Given this list of marker genes Bcl2, Dpp4, Nlgn1, Tbr1, Cep135, Slc44a3, Cd36, Fgf12 (NCBI Gene Id 320320), Sbno2, Map3k8, Cry1, Add3, Calr4, Pdp1, Atad2b, Tg, Etnk1, Ccp110, Pcdh7, Dr1, Hs3st5, Plin3, Traf3ip1, Rest, Six6, Crtc1, Fbxl14 (NCBI Gene Id 101358), Tyr, H2-M10.6, Slc6a1, Ndst4, Fryl, Wrnip1, Jakmip2, Cep152, Gpm6a, Slc52a2, Atad2, Ube2e1, Neurod4, Agfg1, Foxj3, Kcnc4, Btg3, Zfp711, Ceacam19, Rictor, Tagap1, Dact1, Mindy2, Fbxl17, Zfp354b, Prkcb, Slitrk5, Stxbp5l, Cdk19, Ccnh, Cnksr2, Supt7l, Rab2b, Tceal1, Seh1l, Nbea, Hecw2, Stt3a (NCBI Gene Id 16430), Adam10, Slain2, Nrg3, Cap1, Dnm3 (NCBI Gene Id 98663), Tmppe, Rap2c, Kif21a, Fyttd1, Mfsd6, Otx2, Pde4d, Gabrb3, Bpnt2, Slc6a19, Dennd1b, Cysltr1, Elf2, Sh3kbp1, Rab7, Gm6377, Dapk1, 1700010I14Rik, Tbx3, Spock3, Peli1, Lman2l, Kcnmb2, Fermt2, Plp1, Etv1, Kbtbd7, Gucy2f, Vash2, Cyth3, Mcee, Plscr4, Taf1b, Kctd9, Azin1, Cxadr, Extl3, Tspan12, Bmpr1a, Zfp763, Mbp, Srsf11, Ssbp2, G3bp2, Csrnp1, Tmprss11a, Cav1, Crppa, Ino80d, Tshz1, Fam184b, Tagap, Pip4p2, Zfp521, Porcn, Pcdh10, Gatm, Apobec3, Pdlim5, Slc35f4, Cdh7, Kcnv1, Adgrl3, Ankrd42, Rngtt, Aldoc, Klhl5, Prkab2, Apbb2, Nbl1, Tex12, Ntf3, Kcna4, Nwd1, Klhdc2, Nfia, Hnmt, Adgre4, Gpr22, Paxbp1, Ptbp1, Sri, Cpeb2, Naalad2, Epha4, Dtna, Prkar2b, Rtn4rl1, Pgr, Fech, Bcl11a, Ltv1 (LTV1 ribosome biogenesis factor), Stx8, Tmc1, Rtp1, Zfhx4, Dnajb3, Yipf6, Adamts5, Cntn4, Zfpm2, Atosa, Armc8, Syt14, Kdsr, Elmod1, Lsamp, Caprin1, Btbd8, Pik3c2g (NCBI Gene Id 97304), Fli1, Btc, Plpbp, Bmal1, Luc7l3, Lrriq3, Matr3, Mbtd1, 9230112D13Rik, Yeats2, Slc25a2, Lhfpl6, Guf1, Caps2 (NCBI Gene Id 353025), Tpcn1, Dennd6a, Srsf10, here is a description of the gene set: studied in species Mus musculus Genes predicted to be targets of miRBase v22 microRNA mmu_miR_669j in miRDB v6.0 with MirTarget v4 prediction scores > 80 (high confidence targets). Mouse Gene Set: MIR_669J from publication Chen Y, Wang X (PMID 31504780)